The following is a description of a gene set: Mouse Gene Set: GOMF_LIGAND_GATED_MONOATOMIC_ION_CHANNEL_ACTIVITY_INVOLVED_IN_REGULATION_OF_PRESYNAPTIC_MEMBRANE_POTENTIAL Any ligand-gated ion channel activity, occurring in the presynaptic membrane, that is involved in regulation of presynaptic membrane potential. studied in species Mus musculus, and this is the list of marker genes: Grin2b, Gabra5, Gabrb1, Grik4, Kcnma1, Gria2, Grik3, Gria3, Gria1, Glra1, Gabra2, Grin1, Gabra1, Grin3b, Grik2, Grin2d, Gabrr1, Gabra3, Gria4, Gabrb2, Grik1, Htr3a, Grik5, Grin2a